The following is a description of a gene set: Genes down-regulated in cortical thymic epithelial cells (cTEC) versus thymic macrophages. from publication Derbinski J, Gäbler J, Brors B, Tierling S, Jonnakuty S, Hergenhahn M, Peltonen L, Walter J, Kyewski B (PMID 15983066) Human Gene Set: GSE2585_CTEC_VS_THYMIC_MACROPHAGE_DN Gene expression in different thymic stromal cells and subsets thereof was analyzed in 6-12 week old wild type (C57BL/6) and Aire knock-out (mixed background) mice. Thymic stromal cells were purified by sequential enzymatic digestion (collagenase, collagenase/dispase and trypsin) followed by gradient centrifugation and FACS sorting. Sort criteria were as follows: dendritic cells (CD11c+, F4/80 -), macrophages (F4/80+, CD11c-), cTECs (CD45–/lo, CDR1/Ly51+, Ep-CAM+) and mTECs (CD45–/lo, CDR1/Ly51–, Ep-CAM+). mTECs of wild-type and Aire knock-out mice were further subdivided according to CD80 expression levels. For microarray analysis total RNA from thymic stromal cell samples of two independent experiments was pre-amplified and biotinylated by two rounds of cDNA synthesis and in vitro transcription. Fluorescence readings were evaluated by using Microarray Suite 5.0 software. species: Homo sapiens, and this is the list of marker genes: SEPTIN11, CLEC4A, ANXA11, ARL2BP, TACC2, RPS6KA2, F2RL3, RBM47, BHLHE41, SLC6A20, RERG, BRCA2, PAM, UPK1A, NDUFA9, LRFN4, PTGES2, APC, NRAS, GCNT1, RAVER1, OR11H4, CTBP1, CSNK2A1, DDB1, PRKAR1A, LNPEP, BIRC6, FAM76A, USF2, ATP5F1A, SRC, DAAM1, PCBP2, TBL1XR1, ZSWIM8, ZNF687, MYO10, CCSAP, ZSCAN25, SMC2, MPDU1, SPAM1, SRPK3, DNM1, CEP152, GSE1, CITED2, NXNL2, MPHOSPH9, SERPINB12, TBC1D5, STAC2, TFCP2L1, UGGT1, TACC1, SRSF11, NMT2, SLC18B1 (NCBI Gene Id 116843), SETD1B, PLEKHB2, ACOT12, ARPC5, SPRTN, ARHGEF10L, WDR41, UNG, ATP6V0D1, UBE2M, CC2D2A (coiled-coil and C2 domain containing 2A), CDC25B, KLF11 (KLF transcription factor 11), TSPAN7, KIF6, DYRK3, PARP3, RNF40, ELF3, LUZP1, GTF2H3 (general transcription factor IIH subunit 3), NAA40, KLHL42, RARA, DNA2 (DNA replication helicase/nuclease 2), ALG3, AHRR, POLK, NDUFC1, KCTD9 (potassium channel tetramerization domain containing 9), BAX, TNS3, ODF1, SCARNA13, SCGB1A1 (NCBI Gene Id 7356), NCOR1, COA5, ZNF418, PLEC, PPM1H, NHLRC2, OLFM1, ZNF264, SLC12A2, LRFN2, ZNF449, CUL1, NMNAT1, GIT1 (GIT ArfGAP 1), CAV1, SMC1A, TERT, ZNRF3, TMBIM4, RDH12, PTCD2, NOTCH2, INCENP (NCBI Gene Id 56989), ZRANB3, GLRA3, TUBA4A, P2RX5, USP34, STEAP1, AKAP1, TMEM178A, ZC3HAV1, WDFY3, GATAD1, LONRF3, RNF10, HS1BP3, CENPF, SMG7, ANXA1, AK3, TTC28, ITGAL, VWA5A, ILK, MDM2, EIF4G1, FNIP1, CASKIN1, ACSS1, PITPNB, ATP1B1, SIN3B, PTTG1IP, TTC3, CKB, CTDNEP1, RAB1A (NCBI Gene Id 5861), FURIN, RABGEF1, SRXN1, GNAI2, CHAF1B, ANKRD31, SRPRA, SFT2D1, STRAP, SLC29A3, TNKS, TM9SF4, PFKP, MFSD12, RTN4RL2, NF2, MRGBP, AP3S2, MS4A6A, PKDREJ, PAIP1, CPNE2, UQCRFS1, RBM15, CCDC51, WDR35, TBC1D10B, GCFC2, ABCA8, HAS1, KNTC1, EIF2B2, TGIF1, ABCB4, ELAVL1, SH3BGRL3, NCF4, DPYS, TXNDC11 (NCBI Gene Id 96770), TRIM35, COG1, FGFR1, KMT2D, PI4KA, DHX32, DOCK10, GSPT2